The following is a description of a gene set: Reactome Pathway: Negative regulation of FGFR2 signaling Once activated, the FGFR signaling pathway is regulated by numerous negative feedback mechanisms. These include downregulation of receptors through CBL-mediated ubiquitination and endocytosis, ERK-mediated inhibition of FRS2-tyrosine phosphorylation and the attenuation of ERK signaling through the action of dual-specificity phosphatases, IL17RD/SEF, Sprouty and Spred proteins. A number of these inhibitors are themselves transcriptional targets of the activated FGFR pathway. part of: Signaling by FGFR2 species: Homo sapiens, and this is the list of marker genes: PPP2CB, PPP2CA, PTPN11, FGF2, FGF23, FGF22, UBB, BRAF, MAPK1, FGF10, FGF6, PPP2R1A, FGF18, SRC, FGF17, FGF4, FGFR2, FGF16, FGF3 (fibroblast growth factor 3), FGF20, SPRY2, UBC, FGF1, FRS2, FGF7, MAPK3, FGF9, RPS27A, FGF8, CBL, MKNK1, FGF5, GRB2, UBA52